Given this list of marker genes SUCLG2, CS, DLD, PCK1, SDHA, ACLY, OGDH, IDH3A, PDHA1, PC, MDH1, DLST, IDH1, ACO1, DLAT, FH, here is a description of the gene set: studied in species Homo sapiens TCA cycle and deficiency of pyruvate dehydrogenase complex (PDHc) Human Gene Set: WP_TCA_CYCLE_AND_DEFICIENCY_OF_PYRUVATE_DEHYDROGENASE_COMPLEX_PDHC